Given this list of marker genes INPP5E, PTPRQ, PTEN, TPTE2, INPP5D (NCBI Gene Id 653796), TPTE, here is a description of the gene set: species: Homo sapiens Catalysis of the reaction: phosphatidylinositol-3,4,5-trisphosphate + H2O = phosphatidylinositol-4,5-bisphosphate + phosphate. Human Gene Set: GOMF_PHOSPHATIDYLINOSITOL_3_4_5_TRISPHOSPHATE_3_PHOSPHATASE_ACTIVITY